Given this list of marker genes Hspa1a (NCBI Gene Id 193740), Uba52, Jun, Klf6, Junb, here is a description of the gene set: species: Mus musculus Genes negatively differentially expressed in cell type: CD4+ T cell upon treatment with cytokine: TPO in mouse lymph nodes in vivo. from publication Cui A, Huang T, Li S, Ma A, Pérez JL, Sander C, Keskin DB, Wu CJ, Fraenkel E, Hacohen N (PMID 38057668) Cytokines mediate cell-cell communication in the immune system and represent important therapeutic targets. A myriad of studies have highlighted their central role in immune function, yet we lack a global view of the cellular responses of each immune cell type to each cytokine. To address this gap, the authors created the Immune Dictionary, a compendium of single-cell transcriptomic profiles of more than 17 immune cell types in response to each of 86 cytokines (>1,400 cytokine-cell type combinations) in mouse lymph nodes in vivo. A cytokine-centric view of the dictionary revealed that most cytokines induce highly cell-type-specific responses. For example, the inflammatory cytokine interleukin-1β induces distinct gene programmes in almost every cell type. A cell-type-centric view of the dictionary identified more than 66 cytokine-driven cellular polarization states across immune cell types, including previously uncharacterized states such as an interleukin-18-induced polyfunctional natural killer cell state. Mouse Gene Set: CUI_T_CELL_CD4_TPO_RESPONSE_DN